Given this list of marker genes Fgf1, Fgf17, Fgf20, Fgf8, here is a description of the gene set: electronically inferred by orthology from the curated human pathway species: Mus musculus Reactome Pathway: FGFR3b ligand binding and activation part of: FGFR3 ligand binding and activation This event has been computationally inferred from an event that has been demonstrated in another species.<p>The inference is based on the homology mapping from PANTHER. Briefly, reactions for which all involved PhysicalEntities (in input, output and catalyst) have a mapped orthologue/paralogue (for complexes at least 75% of components must have a mapping) are inferred to the other species.